The following is a description of a gene set: studied in species Homo sapiens Increased female libido Human Gene Set: HP_INCREASED_FEMALE_LIBIDO Elevated sexual desire in female, and this is the list of marker genes: CHD7, NHLH2 (nescient helix-loop-helix 2), GNRHR, NSMF (NCBI Gene Id 349336), GNRH1, WDR11, TACR3, HS6ST1, FGF17, KISS1, SPRY4, DUSP6, PROK2, FGF8, FGFR1, PROKR2, KISS1R, TAC3